The following is a description of a gene set: The process, occurring during the embryonic phase, whose specific outcome is the progression of the skeleton over time, from its formation to the mature structure. species: Mus musculus Mouse Gene Set: GOBP_EMBRYONIC_SKELETAL_SYSTEM_DEVELOPMENT, and this is the list of marker genes: Fgfr2, Pcsk5, Mmp16, Pax5, Bmp7, Xylt1, Hoxc4, Hoxd1, Pax7, Eif4a3l1, Tgfb3, Tgfbr2, Hoxa1, Dlx2, Ednra, Dlx5, Obox5, Fuz, Dlx1as (distal-less homeobox 1, antisense), Six1, Lhx1, Obox1, Ift140, Hoxb5, Obox2, Fgf9, Mmp14, Sox11, Wnt9a (NCBI Gene Id 216795), Deaf1 (NCBI Gene Id 54006), Bmi1, Pds5a, Sp3, Flvcr1 (NCBI Gene Id 670389), Hoxb4, Slc39a3, Wnt11, Tapt1, Eif4a3, Ihh, Men1, Runx2, Sp1, Cdk20, Obox3, Myf5, Mef2c, Mbtd1, Fgf8, Tbx1, Hoxb1, Hoxc5, Col11a1, Sulf1, Sulf2, Hoxd3, Zeb1, Mks1, Wnt5a, Hspg2, Chst11, Obox8, Hoxb7, Osr2, Hoxb8, Hoxa4, Mdfi (NCBI Gene Id 17240), Hoxa9, Nodal, Six4, Osr1, Megf8, T, Hoxb3, Shox2, Rdh10, Hoxa7, Ucma, Nog, Hoxd10, Obox7, Foxc2, Axin1, Hoxd11, Slc2a10, Gsc, Slc39a1, Hoxc11, Dmrt2, Etl4, Mosmo, Hoxd9, Hoxa6, Hoxa5, Scx, Col1a1, Shh, Smad3, Hoxa2, Dscaml1, Pbx1, Bmp4, Med12, Pcgf2, 2610005L07Rik, Smad2, Prrx2, Wdr19, Hoxa11, Hoxa3, Pdgfra, Nkx3-2 (NK3 homeobox 2, NCBI Gene Id 12020), Hoxb2, Hoxb6, Twist1, Irx5, Ndst1, Rbp4, Alx3, Dlk1, Tgfb2, Gas1, Mthfd1l, Nipbl, Tgfbr1, Tulp3, Dlx3, Dlx6, Setd2, Col2a1 (NCBI Gene Id 12824), Satb2, Dlg1, Hsd17b7 (hydroxysteroid (17-beta) dehydrogenase 7), Dlx4, Eya1, Wnt9b, Slc35d1 (solute carrier family 35 (UDP-glucuronic acid/UDP-N-acetylgalactosamine dual transporter), member D1), Ext1, Alx1, Tfap2a, Hand2, Six2 (NCBI Gene Id 20472), Twist2, Acvr2a, Ctnnb1, Gnas, Obox6, Asxl2, Eif4a3l2, Hoxc9, Gli3, Hoxd4, Tbx15, Alx4, Hyal1, Dlx1, Mycn, Prrx1, Hoxc6, Dync2i1, Grhl2, Hoxb9